Given this list of marker genes Slc1a2, Gfap, Ntsr1, Slc7a10, Slc1a1, Slc1a3, Prkcd, Nfkbie, here is a description of the gene set: Mouse Gene Set: GOBP_D_AMINO_ACID_TRANSPORT The directed movement of the D-enantiomer of an amino acid into, out of or within a cell, or between cells, by means of some agent such as a transporter or pore. studied in species Mus musculus